The following is a description of a gene set: Human Gene Set: MIR9986 Genes predicted to be targets of miRBase v22 microRNA hsa-miR-9986 in miRDB v6.0 with MirTarget v4 prediction scores > 80 (high confidence targets). studied in species Homo sapiens from publication Chen Y, Wang X (PMID 31504780), and this is the list of marker genes: CCND2, ZNF835, ARRB2, BNC2, DLGAP4, ENPP1, MSR1, LIMD1, TMEM144, C8orf58, VPS9D1, INPP5A, PPARA (NCBI Gene Id 84730), PALD1, PURB, FZD3, TEAD1, PBX1, KCNQ4, NCR3LG1, SEC24C, ZNF714, ATG16L1, CSNK2A2, GPX7, IMPG2, TMOD2, DDX19A, HAS2, DIABLO, DVL3, RGS6, TMPRSS11B, SART3, PRKAA2, FZD4, MEAF6, RBMS2, IARS1, CD164, ADRB1, CLDN12 (NCBI Gene Id 9069), OAS2, ADAMTS1, PTP4A2, SPTBN4, C6orf132, CTBP2, SPTSSB, MYCL, C1GALT1, KIAA0930, SULF2 (NCBI Gene Id 55959), CUX1, SPOCK3, UBE3D, KLHL24, MTOR, ZNF689, PDPR, DMD, YOD1, PIM1, KRT78, RNF126, FARP1 (FERM, ARH/RhoGEF and pleckstrin domain protein 1), NPEPL1, TGFBR1, YIPF1, IGF1R, TRMT13, CHIC1, FNDC3B, BBX, THRSP, LUC7L3, COL4A1, CSRNP3, PAPPA, TECPR2, ZNF33B, MLX, EXT1, CDC34, CLCN5, COL27A1, MAN2A2, SURF4, TAF9B, RAB18, HSPA14, CRK, AGO4, RBFOX2, ARHGEF10L, CCNJL, GNS, USP12, SCN4B, SYT4, KCTD21, KCTD17, SKIL, RNF170, GXYLT1, ADAMTS6, ZNF782, RCN2, DDX19B, PIP4K2C, KRT20, PRRX1, PABIR1, MYC, AMBRA1, SGCG, TMEM26, SEC14L1, ZSWIM4, CXCL8, SERF2, STARD3NL (STARD3 N-terminal like), TCF7L1, TMEM178B, ZNF644, COL4A6, PARM1, BRCC3, NOL4L, ST7L, CDHR1, TRIB2, ARHGAP28, BRWD1, PTPRG, SLC31A2, CFL2 (cofilin 2), CELF2, CYB561D1, MYH9, FHIP2B, FIGN, SCYL2, RGP1, TP53INP1, ADAMTS8, KLHDC8B, AREL1, C14orf28, MACO1, LRCH2, AGO1, RAB3GAP2, NOP14, CBX5, SUCLG2, TENM2, DPAGT1, SEC24A